Given this list of marker genes Cckbr, Ccr2, Shank3, Tshz3 (NCBI Gene Id 338507), Nlgn2, Kmo, Ntrk1, Nrxn1, Grin2d (NCBI Gene Id 14814), Drd1, Cacng2, Rab3gap1, Ptgs2, Adora2a, Cacng4, Glul, Nps, Adcyap1 (adenylate cyclase activating polypeptide 1), Dtnbp1, Nlgn1 (NCBI Gene Id 99949), Ror2, Cacng3, Oxtr, Cacng7, Stxbp1 (syntaxin binding protein 1), Ngfr, Cacng8, Ntrk2, Nlgn3 (NCBI Gene Id 245537), Grin2b, Reln, Grin2c, Ptk2b, Grin2a, Tnr, Egfr, Shank2, Grin1, Hdac6, Iqsec2, Gria4, Ccl2, Cacng5, here is a description of the gene set: Mouse Gene Set: GOBP_POSITIVE_REGULATION_OF_SYNAPTIC_TRANSMISSION_GLUTAMATERGIC species: Mus musculus Any process that activates, maintains or increases the frequency, rate or extent of glutamatergic synaptic transmission, the process of communication from a neuron to another neuron across a synapse using the neurotransmitter glutamate.